The following is a description of a gene set: Genes down-regulated in comparison of dendritic cells (DC) versus Th2 cells. In the present study we used Affymetrix oligonucleotide microarrays to produce gene transcription profiles for the major leukocyte types in humans. This comprehensive dataset enabled us to not only establish which genes were expressed in each leukocyte type, but also which genes were expressed in each subset after activation. The used of a comprehensive dataset of gene profiles from all the major human leukocyte subsets enabled a novel and powerful means for identification of genes associated with single leukocyte subsets, or different immune paradigms. Human Gene Set: GSE3982_DC_VS_TH2_DN studied in species Homo sapiens from publication Jeffrey KL, Brummer T, Rolph MS, Liu SM, Callejas NA, Grumont RJ, Gillieron C, Mackay F, Grey S, Camps M, Rommel C, Gerondakis SD, Mackay CR (PMID 16474395), and this is the list of marker genes: TXNDC15, APOBEC3G, DOLPP1, TRAPPC2, LCK, TYMS, EXOSC9, CXCR6, ORC1, BCL2L14, DDX18, NT5E (5'-nucleotidase ecto), TSPYL2, UBE2D2, TPD52, TPR, SP140, FTSJ1, HARS1, KIF20A, DNAJC9, PSMA2, MRPL49, GSC2, HDDC2, PERP, HNRNPF, MRPS18C, ADAM22, GABPB1, MAP7D3, GINS3, RMND1, CHST2, CHRNB4, TUBA4A, PAXIP1, SEPTIN8, CCL4, MRPS15, STC1, HYOU1, CD2, IL13RA2, KIF21B, NCBP1, RAB23, PTMA, SPC25, CA14, ZEB1, TFDP1, MPHOSPH9, MRPL39, TMSB15B, SF3A1, ITGAL, RAD51C, SERPINE2, VRTN, STAG3L1, RYR2, TFF3, MICAL2, AMIGO2, NRN1, WWC3, FAM117A, PRDX2, BACH2, GUCY1A2, CCNB1IP1, SLC39A14, FANCI, RPL6, ECI2, CEP131, POGLUT2, RPIA, SEPHS1, QRSL1, AHI1, OR1G1, SPTBN2, CTCF, EIF4G1, RFC3 (replication factor C subunit 3), PMAIP1 (NCBI Gene Id 9305), ATAD2, HEG1, STON1, DPY19L2P2, SNRPD3, CCNB2, GPSM2, SLCO1C1, SLC6A5, TROAP, PTTG1, BIRC5, BICRAL, DLG3, PDCD5, PDE4D, SLC35E1, DIS3, NASP, TMEM39A, TRA2A, IL18R1, THBS4, TAGLN2, XRCC5, CENPF, PNP, SPTBN1, DLGAP5, USP11, ARHGAP5, FAM216A, E4F1, RPA3, PSMC4, RRM1, HOXB9, RAN, KIF2C, ARHGAP11A, HMMR, SOCS1, AAMP, CCP110 (centriolar coiled-coil protein 110), RPL36AL, POLQ, RBM14, GLOD4, MAP3K7 (NCBI Gene Id 6885), CD72, MRPL42, MYB, TRIP13, ING3, TRAC, ASF1B, ZNF142, NLGN4Y, TWIST1 (NCBI Gene Id 7967), GALNT3, CCNA2, PTGS2, GINS4, B3GAT3, PCID2, FASLG (NCBI Gene Id 356), MIS18BP1, TRMT5, ARHGAP35, LAPTM4B, ZNF281, MDN1, HNRNPAB, SOCS2, CNKSR1, ARHGEF6, TSPAN13, GATA3, COX10, ICOS, H2BC11, CYP2C18, MARCKSL1, SUPT16H, DCTN6, NAB1, ARID5B, KIF15, RFC4, TESC, BCL2, ANKRD11 (ankyrin repeat domain containing 11), OIP5, AGK, STAP1, HLA-F-AS1 (NCBI Gene Id 285830), MB, SFXN1 (sideroflexin 1), MRPL13, RHOH (NCBI Gene Id 399), CENPN, DSG2, IL24, PASK, ZDHHC14, NUP37 (NCBI Gene Id 79023), ASCL3, HIRIP3, SYNE2, ZNF334, UBR7